Given this list of marker genes Krtap24-1, Akirin1, Abraxas2, Ucn2, Cstpp1, Lrrc66 (leucine rich repeat containing 66), Mbd2, Ldlrad3, H2-Q10, Tpcn2, Iffo2, Osbpl6, Zfp503, Gprc5a, Sh2d3c, Clrn1, Dnajc16, 2700062C07Rik, Fbxl18, Pcdh10, Glcci1, Ccr1, Stk26, Map3k3, Eef2k, Bmp15, Alkbh1, Kcna2, Snu13, Fam169b, Esrrg, Hyal1, Vcf1, Kmt2a, Cracd, Atg9b, Asxl2, Trmt112, Cdk7, Ncan, Aste1, Rnf41, A830018L16Rik, here is a description of the gene set: from publication Chen Y, Wang X (PMID 31504780) Genes predicted to be targets of miRBase v22 microRNA mmu_miR_28c in miRDB v6.0 with MirTarget v4 prediction scores > 80 (high confidence targets). Mouse Gene Set: MIR_28C species: Mus musculus